The following is a description of a gene set: studied in species Homo sapiens The attachment of a cell, either to another cell or to an underlying substrate such as the extracellular matrix, via an integrin, a heterodimeric adhesion receptor formed by the non-covalent association of particular alpha and beta subunits. Human Gene Set: GOBP_CELL_ADHESION_MEDIATED_BY_INTEGRIN, and this is the list of marker genes: ADAM17, ITGA5, IFT74, ITGAV, ITGB1, SFRP2, CRK, ITGA6, CCL21, ITGA4, ITGB6, SWAP70, NEXMIF, FOXC2, ITGA11, ITGA3, WNK1, CXCL13, EPHA8, PDE3B (NCBI Gene Id 5140), PTPN11, PTK2, PIEZO1, ITGB2, ITGB4, EMILIN1, CD3E, EPHA2, ACER2, ICAM1, LIF, NPNT, COL16A1, MMRN1, CRKL, FYB2, ITGA10, ITGA2, ITGB5, DPP4, ADAM9, CYP1B1, CCL5, SERPINE1, HRG, EXT1, ADA, FERMT3 (FERM domain containing kindlin 3), PODXL, JAM3, LPXN, ITGAM, EFNA1, MUC1, ITGA8, PLAU, ITGB3, ITGA9, NCKAP1L, TESC, EMILIN2, PLPP3, ITGB8, ITGA1, PIK3CG, VTN, SYK, PTPN6, TGFB2, SKAP1, P2RY12, RAC3, CIB1, SNAI2, ITGAX, ITGA2B, ITGBL1, ITGB1BP1, ITGA7, ITGAL, ITGAE, CCN3, ITGB7, FBN1, RET, FERMT1, LYN, ITGAD, VCAM1